Given this list of marker genes HYCC1, CACNA1B, GM2A, ITPRID2, FLRT2, TRIB1 (tribbles pseudokinase 1), MYO1E, MIR22HG (NCBI Gene Id 84981), KRT32, CDH7, NXPH3, CTXN1, CDON, PLBD1, MIDEAS, ENTPD6, FOSL1, TIPARP, SMAD3, SCN1A (NCBI Gene Id 6323), TIGD5, CD96, CXADR, RASD1, TMEM74B, TGFB3, PLEK, BEX3, DNAJB13, CGRRF1, SH2D2A, PTPRN, TNFRSF13C, ABCD1, NRP2, ATOH8, ALCAM, RMND5B, PGR, NXF3, RBPMS2, RAB20, SFTPB, RBPJ, DUSP3, TOX2, TMEM51, TGFB1, PLAGL1, STARD8, SPP1, C5orf47, SPAG16, LBH, PRKCA, NR4A2, TMT1B, NR4A3, FOSL2, BLK, RASGEF1B, EGR2, TMEM54, IL6ST, NAB2, ORAI1, CHD3, C17orf100, TUBE1, GRHL1, SACS, NSMF, PLOD2, FSTL5, HIC1, SYCE2, ITGAV, WNT10A, TOB2, AHR, GNAT1, CREB5 (NCBI Gene Id 9586), PFKP, XCL1, MYO1D, PSAP, AMZ1, F2RL1, OSBPL3, SOX4, SCG2, PMP22, IL13RA1, CABYR, WFS1, DVL2, MAP2K3, WDR90, VSIG1, GRIPAP1, DUSP4, KCNA5, LRRC8D, UBL4B, TM4SF20, SLC15A3, IL1R2, IGF2BP2, RETREG1 (reticulophagy regulator 1), FGF12, EGR1, CERCAM, EPHX1, WNT1, LAT2, CHST11, ANO6, WDR64, VPREB3, RIMBP3C, LIPG, S1PR3, ATP6V0D1, SLC17A5, TAGAP, HRH2, HMGCLL1, RHOF, IFITM2, APOC4, KANK3, VPS26B, DUSP6, FADS1, ZC3H12C, LCK, RPS6KA2, HIVEP3, FABP5, RENBP, SLC17A9, NFATC1, FRAS1, PREX2, DNAH2, TPST2, RGS3, SLC6A19, PRDM8, GLA, SLCO4A1, ADAMTS10, RGS2, MDFIC, SARS1, HPGDS, UCP1, TLCD3A, ZDHHC18, RAB39B, DHTKD1, MLANA, MUSK, MALT1, XBP1, GFI1, NRGN, CD27, HSF5, FCER1A, RILPL2, VCL, LONRF3, UAP1L1, CST7, PRND, CFAP161, CD33, BNC1, KCNK13, GPR35, RGS13, ABCA2, GNG4, RNF17, SEMA4D, SLC18A1, PARD6G, M6PR, ATP6V0B, VEGFC, IER2 (NCBI Gene Id 9592), BEX1, MMP7 (NCBI Gene Id 4316), SLC5A11, GAA, IL33, EGR3, MADCAM1, here is a description of the gene set: Human Gene Set: GSE43863_TFH_VS_LY6C_LOW_CXCR5NEG_EFFECTOR_CD4_TCELL_DN CD4 T follicular helper (Tfh) cells provide the required signals to B cells for germinal center reactions that are necessary for longlived antibody responses. However, it remains unclear whether there are CD4+ memory T cells committed to the Tfh lineage after antigen clearance. Using adoptive transfer of antigen-specific memory CD4+ subpopulations (based on CXCR5 and Ly6c expression)in the LCMV infection model, we found that there are distinct memory CD4+ T cell populations with commitment to the Tfh and Th1 lineages. Our conclusions are based on gene expression profiles, epigenetic studies and phenotypic and functional analysis. The gene expression profiles of virus-specific CD4 T cell subets at effector and memory stages is presented here. species: Homo sapiens from publication Hale JS, Youngblood B, Latner DR, Mohammed AU, Ye L, Akondy RS, Wu T, Iyer SS, Ahmed R (PMID 23583644) Genes down-regulated in CD4 SMARTA effector T cells during acute infection of LCMV: follicular helper (Tfh) versus Ly6c low CXCR5-.